Given this list of marker genes STAT3, JAK2, CHRNA4, CCND1, CHRNB2, here is a description of the gene set: Nicotine to Jak-STAT signaling pathway. Pathway ID: N01342. Pathway type: Env factor. Pathway class: nt06219 JAK-STAT signaling. Pathway Definition from KEGG: Nicotine -> (CHRNA4+CHRNB2) -> JAK2 -> STAT3 => CCND1 species: Homo sapiens Human Gene Set: KEGG_MEDICUS_ENV_FACTOR_NICOTINE_TO_JAK_STAT_SIGNALING_PATHWAY